The following is a description of a gene set: Intracellular mass of paired, helically wound protein filaments (also called PHF) lying in the cytoplasm of neuronal cell bodies and neuritic cell processes. Neurofibrillary tangles contain an abnormally phosphorylated form of a microtubule-associated protein, tau. The shape of these inclusions may resemble a flame or a star. Human Gene Set: GOCC_NEUROFIBRILLARY_TANGLE studied in species Homo sapiens, and this is the list of marker genes: PICALM, MAPT, NEFH, CLU, NEFM